The following is a description of a gene set: Human Gene Set: HALLMARK_DNA_REPAIR Genes involved in DNA repair. from publication Liberzon A, Birger C, Thorvaldsdóttir H, Ghandi M, Mesirov JP, Tamayo P (PMID 26771021) species: Homo sapiens, and this is the list of marker genes: SF3A3, RPA2 (NCBI Gene Id 6118), NCBP2, POLR2C, FEN1, GUK1, TP53, RALA, GMPR2, SEC61A1, RFC2, POLR1C, PRIM1, POLA2, ALYREF, PDE6G (phosphodiesterase 6G), RBX1, GTF2A2, ADA, SDCBP, VPS28, ERCC1, SSRP1, DCTN4, DDB1, DUT, PCNA, SMAD5, TARBP2, ZWINT, GTF3C5, POLR2F, ERCC4, POLR2G, BOLA2, ELL, EDF1, HPRT1, SURF1, CETN2 (centrin 2), NME1, TAF6, POLL, ELOA, NME4, VPS37D, NUDT21, POLR2H, TSG101, POLA1, POLR2D, SNAPC5, BCAM, POLE4, APRT, TAF1C, XPC, IMPDH2, TAF12, ERCC8, ERCC5, RAE1, SNAPC4, MPC2, RFC4, NELFCD, POLR2I, TAF10, AGO4, POLR2A, RAD51, PDE4B, NELFE, CLP1, PNP, NFX1, GTF2F1, RAD52, MRPL40, BRF2, DGUOK, DDB2, POLD1, ERCC3, POLH, CCNO, POLR2K, POLR1H, GSDME (NCBI Gene Id 1687), ADRM1, CDA, POLR3GL, ITPA, AAAS, STX3, GTF2B, BCAP31, TK2, RPA3, RFC3, GTF2H3, POLR3C, POLR2E, ERCC2, POLR1D, TYMS, HCLS1, COX17, AK1, POLD3, ADCY6, POM121, CMPK2, CANT1, SAC3D1, DGCR8, TAF9, LIG1, VPS37B, ZNF707, SUPT4H1, POLD4, RRM2B, EIF1B, USP11, GTF2H1, NELFB, CSTF3, UPF3B (NCBI Gene Id 65109), NME3, ARL6IP1, NT5C3A, RNMT, POLR2J (RNA polymerase II subunit J), GPX4, AK3, TAF13, SRSF6, POLB, UMPS, NT5C, SUPT5H, REV3L, NUDT9, RFC5, TMED2, DAD1, NPR2, MPG, GTF2H5